The following is a description of a gene set: Human Gene Set: REACTOME_ACTIVATION_OF_APC_C_AND_APC_C_CDC20_MEDIATED_DEGRADATION_OF_MITOTIC_PROTEINS Activation of APC/C and APC/C:Cdc20 mediated degradation of mitotic proteins studied in species Homo sapiens, and this is the list of marker genes: RPS27A, CDC16, PSMC6, PTTG1, CCNA1, ANAPC2, PSMC2, PSMD13, PSMC4, CDC20, PSMC3 (NCBI Gene Id 96121), CCNA2, UBE2D1 (NCBI Gene Id 9335), MAD2L1, PSMB7, PSMD3, PSMA6 (proteasome 20S subunit alpha 6), CCNB1, PSMB3, PSMB2, PSMD11, PSMC5, ANAPC1, UBA52, CDC23, PSMD1, UBE2C, ANAPC10 (anaphase promoting complex subunit 10), SEM1 (NCBI Gene Id 7979), CDK1, PSMA7, NEK2, PSMD12, UBC, ANAPC4 (anaphase promoting complex subunit 4), PSMD6, UBB, PSMD14, PSMB4 (NCBI Gene Id 5692), BUB3, PSMB6, ANAPC16, UBE2S, CDC27, PSMB1, PSMA1, PSMA4 (proteasome 20S subunit alpha 4), PSMD8, PSMA2, PSMB5, ANAPC5, PSMA5, PSMC1, ANAPC7, PSMA3, ANAPC11, PLK1, ANAPC15, PSMD7, CDC26, ADRM1, PSMD2, UBE2E1, BUB1B